The following is a description of a gene set: from publication Hoek KL, Samir P, Howard LM, Niu X, Prasad N, Galassie A, Liu Q, Allos TM, Floyd KA, Guo Y, Shyr Y, Levy SE, Joyce S, Edwards KM, Link AJ (PMID 25706537) species: Homo sapiens Genes down-regulated in T cell 1d vs 0d in adults after exposure to 2011-2012 trivalent inactivated vaccine (A/California/7/09 (H1N1), A/Perth /16/2009 (H3N2), B/Brisbane/60/2008), time point 1D. Comment: Down-regulated DE RNA transcripts (down >= 1.5x) shared between both TIV-vaccinated donors Systems biology is an approach to comprehensively study complex interactions within a biological system. Most published systems vaccinology studies have utilized whole blood or peripheral blood mononuclear cells (PBMC) to monitor the immune response after vaccination. Because human blood is comprised of multiple hematopoietic cell types, the potential for masking responses of under-represented cell populations is increased when analyzing whole blood or PBMC. To investigate the contribution of individual cell types to the immune response after vaccination, we established a rapid and efficient method to purify human T and B cells, natural killer (NK) cells, myeloid dendritic cells (mDC), monocytes, and neutrophils from fresh venous blood. Purified cells were fractionated and processed in a single day. RNA-Seq and quantitative shotgun proteomics were performed to determine expression profiles for each cell type prior to and after inactivated seasonal influenza vaccination. Our results show that transcriptomic and proteomic profiles generated from purified immune cells differ significantly from PBMC. Differential expression analysis for each immune cell type also shows unique transcriptomic and proteomic expression profiles as well as changing biological networks at early time points after vaccination. This cell type-specific information provides a more comprehensive approach to monitor vaccine responses. Human Gene Set: HOEK_T_CELL_2011_2012_TIV_ADULT_1DY_DN, and this is the list of marker genes: NTSR1, CCR9, MORN1 (NCBI Gene Id 79906), NICOL1, TRIM74, UPK2, TOB1-AS1